Given this list of marker genes Cplx1, Syt1, Syn1, Rab3a, Syn3, Vamp2, Stx1a, Ppfia2, Ppfia3, Tspoap1, here is a description of the gene set: This event has been computationally inferred from an event that has been demonstrated in another species.<p>The inference is based on the homology mapping from PANTHER. Briefly, reactions for which all involved PhysicalEntities (in input, output and catalyst) have a mapped orthologue/paralogue (for complexes at least 75% of components must have a mapping) are inferred to the other species. part of: Neurotransmitter release cycle Reactome Pathway: Serotonin Neurotransmitter Release Cycle electronically inferred by orthology from the curated human pathway studied in species Mus musculus